The following is a description of a gene set: Cytokines mediate cell-cell communication in the immune system and represent important therapeutic targets. A myriad of studies have highlighted their central role in immune function, yet we lack a global view of the cellular responses of each immune cell type to each cytokine. To address this gap, the authors created the Immune Dictionary, a compendium of single-cell transcriptomic profiles of more than 17 immune cell types in response to each of 86 cytokines (>1,400 cytokine-cell type combinations) in mouse lymph nodes in vivo. A cytokine-centric view of the dictionary revealed that most cytokines induce highly cell-type-specific responses. For example, the inflammatory cytokine interleukin-1β induces distinct gene programmes in almost every cell type. A cell-type-centric view of the dictionary identified more than 66 cytokine-driven cellular polarization states across immune cell types, including previously uncharacterized states such as an interleukin-18-induced polyfunctional natural killer cell state. Mouse Gene Set: CUI_CDC1_IL33_RESPONSE_UP from publication Cui A, Huang T, Li S, Ma A, Pérez JL, Sander C, Keskin DB, Wu CJ, Fraenkel E, Hacohen N (PMID 38057668) studied in species Mus musculus Genes positively differentially expressed in cell type: cDC1 (conventional dendritic cell type 1) upon treatment with cytokine: IL-33 in mouse lymph nodes in vivo., and this is the list of marker genes: Irf5, Basp1, Atp6v1a, Prkcd, Ifi205, Gatm, Cd274, G3bp1, Wfdc17, Swap70, Snn, Cd53, Cish, Slfn2, Nlrp3 (NCBI Gene Id 216799), Tmem131, Trib1, Glipr2, Ccl12, Mtss1, Tspo (NCBI Gene Id 12257), Trim30a, Srgn, Nrros, Nlrc5 (NCBI Gene Id 434341), Esf1 (NCBI Gene Id 99391), Picalm, Ak2, Cpne2 (copine II), Cct3, Sh3glb1, Mab21l3, Lgmn, Tes (testin LIM domain protein), Chd7 (chromodomain helicase DNA binding protein 7), Trio, Eif4e, Clic4 (chloride intracellular channel 4), Ppa1, Rras2, Ccdc86, Ifitm2, Srsf2, Jak2, Edem1, Tnip3 (TNFAIP3 interacting protein 3), Snx2, Batf3, C1qc, Ms4a6d, Lcp1, Ly6e, Cd300a, Serpina3g, Ccl17, Pim1, Vamp8, Mbd2, Casp6, Malt1 (NCBI Gene Id 240354), Spred1, Csrnp1, Hfe, Casp4, Ndrg1, Apol7c (NCBI Gene Id 73662), Pfkp, Nabp1, Cd40, Ier3, Arhgap22, Fnbp1l, Cxcl9, Sdc4, Snx3, Efhd2, Mllt6, Stat5a, Eif6, Bcl2a1d, Pdcd1lg2, Fam241a (NCBI Gene Id 97083), Sipa1l3, Socs3, Ogfr, Tmem131l, Frmd4a, Ptger4, Arf3, Rars1, Lap3, Ctsz, Denr, Kmo, Cflar, Gbp5, Rara, Ccnd2, Rrbp1, Cdkn1a, Acp5, Socs1, Mkrn1, Gnb4, Syngr2, Slc30a4, Irf7, Rab2a, Litaf, Arl8b, Riok3, Coro2a, Eps8, Cst3, Ifi204, Svbp, Ptpn1, Rap2a, Pnp, Slc33a1, Esyt2